The following is a description of a gene set: Mouse Gene Set: TSENG_ADIPOGENIC_POTENTIAL_UP from publication Tseng YH, Butte AJ, Kokkotou E, Yechoor VK, Taniguchi CM, Kriauciunas KM, Cypess AM, Niinobe M, Yoshikawa K, Patti ME, Kahn CR (PMID 15895078) Genes showing increasing expression in brown preadipocytes with decreasing ability of the cells to differentiate. The insulin/IGF-1 (insulin-like growth factor 1) signalling pathway promotes adipocyte differentiation via complex signalling networks. Here, using microarray analysis of brown preadipocytes that are derived from wild-type and insulin receptor substrate (Irs) knockout animals that exhibit progressively impaired differentiation, we define genes/expressed-sequence tags whose expression in preadipocytes correlates with the ultimate ability of the cells to differentiate. Many of these genes, including preadipocyte factor-1 (Pref-1) and multiple members of the Wnt signalling pathway, are related to early adipogenic events. Necdin is also markedly increased in Irs knockout cells that cannot differentiate, and knockdown of necdin restores brown adipogenesis with downregulation of Pref-1 and Wnt10a expression. Insulin receptor substrate proteins regulate a necdin-E2F4 interaction that represses peroxisome-proliferator-activated receptor gamma (PPARgamma) transcription via a cyclic AMP response element binding protein (CREB)-dependent pathway. Together these define a key signalling network that is involved in brown preadipocyte determination. studied in species Mus musculus, and this is the list of marker genes: Glrb, Ch25h, Col7a1, Rnf227, Cdkn2b, Tcf7, Ddx47, Dbnl, Trib3, Wnt10a, Bpgm (2,3-bisphosphoglycerate mutase), Klra4, Bmp6, Ccn4, Rhou (ras homolog family member U), Efnb2, Nnat, Adora2b, Cars1, Mthfd2, Ptprf, Dlk1, Prss23, Ndn, Uck2, Fhl1, Gjb3, Crabp2, Mapk12, Cd24a, Mgp